The following is a description of a gene set: Human Gene Set: GSE22342_CD11C_HIGH_VS_LOW_DECIDUAL_MACROPHAGES_UP Decidual macrophage populations, CD11cHI and CD11cLO cells were analyzed for expression profiles and unique characteristics. We used microarrays to detail the global program of gene expression and to determine differences between these two unique decidual macrophage populations. from publication Houser BL, Tilburgs T, Hill J, Nicotra ML, Strominger JL (PMID 21257965) Genes up-regulated in decidual macrophages with ITGAX high versus low. studied in species Homo sapiens, and this is the list of marker genes: STIM1, AMIGO2, OR6M1, PFKFB1, SNORD73A (small nucleolar RNA, C/D box 73A), SLC35E3, PRIM1 (NCBI Gene Id 5557), RACGAP1, USP32, TNFRSF1A, PRADC1, AHSA2P (activator of HSP90 ATPase homolog 2, pseudogene), CSN1S2AP, AMFR, KRIT1, CHST8, HFE (homeostatic iron regulator), CHD9, DNA2, CXCR2, KIAA0825, PGBD1, ZNF426, NEDD4, AKR1C4 (aldo-keto reductase family 1 member C4), DNAJC18, VWA8, AKR1C3, NSG1, TNFRSF17, GOSR1, PTPMT1 (protein tyrosine phosphatase mitochondrial 1, NCBI Gene Id 114971), MARF1, KIF13A, PPP6R3, SLC25A51 (solute carrier family 25 member 51), FAM169A, GDPD5 (NCBI Gene Id 81544), MYH9, ADAMTS6, MUC15, CD58, SEC24B, PRR15, TNNI2, SNRNP70, ZNF407, DTHD1, TSPAN31, RBM41, ORMDL2, PTCH1, C2CD5, PRKCI, MDGA2, MAP4K3, SSU72, PSD2, SLITRK6, DNAJC3, NAA35, ATAD2, TRUB1, POLE4, EXTL3, SSMEM1, CABYR, BOD1, ZNF681, SLC16A14, PTGES2-AS1, CDC42SE1 (NCBI Gene Id 56882), CARS1, RGS9 (NCBI Gene Id 8787), AP1M2, TMEM248, DEFB135, STARD13, ESRRG, BAG4, EFCAB3, ITGAL, PTGER2, RPL31, SNORD115-37, PLEK, PSMB2, BBX, AMDHD2, CYP4F8, CAPZB, CFAP300, CHP1P2, ENDOD1, MAPK14, CLEC5A, MLLT6, PBX4, MGAT2, OR52L2P, NIPA2, GLRX2, YEATS2, UQCRH, SLC9C2, VNN2, SPPL3 (NCBI Gene Id 25881), LAMA2, RIMS2, HCAR1, PLD3, ZNF319, SUCNR1, RBM11, UTP3, NCOR1, GPR174, ZNF516, ZNF746, CTH, FAM8A1, ABI2, PRNP, MYO5A, RASSF6, R3HDM2, ST3GAL3, FAM20A, AP2M1, DCP1A, PHIP (NCBI Gene Id 83843), TMEM207, TTYH3, GORAB, TRAPPC10, IKZF1, OR7E5P, EIF4G3, GM2A, AHNAK, FLNA, NUDT3, SMIM15, CYTH1, PSMC1, DENND6A, MTERF2, LINC00469, APOL4, NFIL3, HGSNAT, MAGOH, DMRT2, QKI, DBNL, SH3D19, POLR1B (RNA polymerase I subunit B), RABEPK, ENPP5, CA1 (NCBI Gene Id 759), GNPTAB, BFSP1, ZRSR2P1, NINL, KBTBD3, ADAM7, EPG5, WDR5B, VCPIP1, FIGNL1, ALDH7A1, CCDC180, GSTA2, TBC1D2B (NCBI Gene Id 91449), WDR64, RNU6ATAC, DEFB116 (NCBI Gene Id 245930), TNNC1, AFG2B, GTPBP6, ZNF570, DXO, PPP2R5C, RAB18, FAM221B, TNRC6A, CYP4F2, BRDT, SNORD116-10, APAF1, MAB21L2, SMC3, MFSD13A, NGEF (NCBI Gene Id 25791), TAAR9 (trace amine associated receptor 9), LRRC8A, WIPI1, RNF216